The following is a description of a gene set: Human Gene Set: HP_INCREASED_CIRCULATING_INSULIN_LIKE_GROWTH_FACTOR_1_CONCENTRATION An elevated level of insulin-like growth factor 1 (IGF1) in the blood circulation. species: Homo sapiens Increased circulating insulin-like growth factor 1 concentration, and this is the list of marker genes: PRKAR1A, MEN1 (menin 1), AIP, IGF1R, GPR101, PDE11A